The following is a description of a gene set: The half-life of Cx is very short (1 to 5h) compared to other junctional proteins. Connexins are targeted for degradation by the proteasome and the lysosome. Degradation appears to involve the phosphorylation of Connexins as well as their interactions with other proteins. part of: Gap junction trafficking Reactome Pathway: Gap junction degradation species: Homo sapiens, and this is the list of marker genes: ACTB, AP2M1, ACTG1, CLTCL1, DNM2, CLTA, GJA1, CLTC, DNM1, DAB2, MYO6, CLTB